Given this list of marker genes Ubr5, Ubr4, Ubr2, Ubr1, Ubr3, here is a description of the gene set: Mouse Gene Set: GOBP_UBIQUITIN_DEPENDENT_PROTEIN_CATABOLIC_PROCESS_VIA_THE_N_END_RULE_PATHWAY studied in species Mus musculus The chemical reactions and pathways resulting in the breakdown of a protein or peptide covalently tagged with ubiquitin, via the N-end rule pathway. In the N-end rule pathway, destabilizing N-terminal residues (N-degrons) in substrates are recognized by E3 ligases (N-recognins), whereupon the substrates are linked to ubiquitin and then delivered to the proteasome for degradation.